Given this list of marker genes B3gnt2, Ube2c, Gm24665 (predicted gene, 24665), Slc2a3, Tjp2, Timm13, Trim34a, Eif5a, Hoxa11, Ube2i, Mlxip, St7, Bcl2l12, Kntc1, Dnajc11, Lonrf2, Pgap2, Banp, Tor1aip1, Dlk1, Pdzd9, Stx3, Cenpi, Amigo1, Tex14, Mkks, Myo1c (NCBI Gene Id 97728), Gm6345, Setd1a, Ywhag, Fcgr3, Uba5, Gm15651, Kif2c, Kpna2, Uvrag, Gm17806, Gm9726, Gm16096, Acer2, Nbr1 (NCBI Gene Id 17966), Snf8, Hspa4, Gamt, Vamp1, Mir302b, Rpl5, Gm9506, Clec2d, Taf1d, Rora, Wdfy3, Zbtb7a, Spcs1, Speg, Cep95, Zwilch, Smg7, Tm4sf5, Nup160, Vps72, Zfp438, Pou2f2, Uba1, Dpy30, Sass6 (SAS-6 centriolar assembly protein), 2900079G21Rik, Cltc, Irf3, Zdhhc5, Rsrc2, Shoc1, Strn4, Jakmip1, Ccdc65, Med18, Prpf19, Mir302c, Dhrs3, Kank3, Syngr4, Sult2b1, Mob3a, Mfge8, Ipo13, Sirt7, Spink10, Ighg1, H4c16, Pacrg, Bola2, Tbc1d9b, Abhd16a, Psma3, 1700022A21Rik, Hoxa7, Hoxa3, Yars1, Lyl1, Eif1ad8, Abtb3 (NCBI Gene Id 74007), Mxd3, Arl2bp, Fgfr1op2, Mrpl9, Bcl2l1, Usp14 (NCBI Gene Id 98113), Ercc6l, S100pbp (NCBI Gene Id 74648), Saraf, Zbtb8a, Ino80d, Prss36, Gm14098, Hspa9, Esyt2, Mcf2l, Rad51c, Pde4d (phosphodiesterase 4D, cAMP specific), Ppp4r4, Gm15782, Mis18bp1, Tyw1, Eif3k, Gfi1, Cbfb, Tram1, Rfwd3, Dll1, Ift172, Gm4349, Ckap2, Vdr, Ing3, 5031434O11Rik, Inpp5b, Safb, Gm12740, Papss2, Carhsp1, Agap3, Nfxl1, Zfp395, Izumo4, Tpk1 (NCBI Gene Id 29807), Tet1, Thrap3, Nop58, Sinhcaf, Sptan1, Zfp747l1, Gm5532, Capza1, Tmem143, Gm13110, Satb2, a, Plcxd2, Dlgap5, Gm22122, Rps6-ps3, Epha10, Gm12339, Mir302a, Phf20, Lbr, Ninj2, Itih3, Adipor2, Arpp21, Psmb6, Rex1bd, Mvd, Gm6736, Fam117a, Phox2b, Scn9a, Nipbl, Prkrip1, Srsf1, Ddb2, Cnbd2 (NCBI Gene Id 71343), Manba, Nbeal2, Fbxl22, 1110028F18Rik, Ogt, Gga2, A430072P03Rik, Slfn5, Pigb, Gm24296, C230066G23Rik, 4933440N22Rik, Stradb, Atrnl1, Mdk, Arrdc3, Tsc22d4, Gm12980, Mir367, Rbm47, Shmt1, Dnajb2, Slx4ip, Hsp90ab1, Wdr75, Ppfibp2, Tatdn2, Trp53rka, Chrna10, Smtn, Luc7l2, Lamtor3, Hoxa11os, Eif2ak4, Hexim2, Fkbp7, Mroh1, Dars2, Chsy1, Tra2b, Ino80dos, Tor1aip2, Atoh1, Gm24204, Rere, Znrf1, Mir302d, Usp1, Acad11, here is a description of the gene set: from publication Yevshin I, Sharipov R, Kolmykov S, Kondrakhin Y, Kolpakov F (PMID 30445619) studied in species Mus musculus Mouse Gene Set: GM14296_TARGET_GENES